Given this list of marker genes FOXO3, JAK2, SESN3, SESN1, CCNG1, TNFRSF11A, CACNA1E, ING4, CDKN1C, ENPP2, RFFL, CACNG3, TFDP2, CARD6, CDKN2C, STAM, PDE3B (phosphodiesterase 3B), IP6K2, TP53INP1, CDKN1B, PROK2, RGPD4, PTPRC, PLCB1, SOS1, NT5E, PDCD4, CASP1, PIK3R3, CCNG2, FAS, MAP2K6, LGALS12, DAPK1, ATM, PDGFC, here is a description of the gene set: species: Homo sapiens In this study, we compared the effects of interleukin-2 (IL-2), IL-15, and IL-21 on gene expression, activation of cell signaling pathways, and functional properties of cells derived from CD4+ cutaneous T-cell lymphoma (CTCL). Whereas both IL-2 and IL-15 modulated, in a CTCL cell line, the expression of >1,000 gene transcripts by at least 2-fold, IL-21 up-regulated <genes. All three cytokines induced tyrosine phosphorylation of Jak1 and Jak3 in CTCL cell lines and native leukemic (Sezary) cells. However, only IL-2 and IL-15 strongly activated signal transducers and activators of transcription 5, phosphoinositide 3-kinase/Akt, and mitogen-activated protein/extracellular signal-regulated kinase (ERK) kinase/ERK signaling pathways in the cell lines and mitogen-primed native cells. In contrast, IL-21 selectively activated signal transducers and activators of transcription 3. Whereas all three cytokines protected CTCL cells from apoptosis, only IL-2 and IL-15 promoted their proliferation. The effects of the cytokine stimulation were Jak3 kinase- and Jak1 kinase- dependent. These findings document the vastly different effect of IL-2 and IL-15 versus IL-21 on CTCL cells. They also suggest two novel therapeutic approaches to CTCL and, possibly, other CD4+ T-cell lymphomas: inhibition of the Jak1/Jak3 kinase complex and, given the known strong immunostimulatory properties of IL-21 on CD8+ T, natural killer, and B cells, application of this cytokine to boost an immune response against malignant CD4+ T cells. from publication Marzec M, Halasa K, Kasprzycka M, Wysocka M, Liu X, Tobias JW, Baldwin D, Zhang Q, Odum N, Rook AH, Wasik MA (PMID 18281483) Human Gene Set: MARZEC_IL2_SIGNALING_DN Genes down-regulated by IL2 in cells derived from CD4+ cutaneous T-cell lymphoma (CTCL).